The following is a description of a gene set: species: Homo sapiens Human Gene Set: GOMF_MOLECULAR_ADAPTOR_ACTIVITY The binding activity of a molecule that brings together two or more molecules through a selective, non-covalent, often stoichiometric interaction, permitting those molecules to function in a coordinated way., and this is the list of marker genes: CBX2, STRIP1, ZNF432, KCTD17, TOB2, FBXL2, DNAJC2, NUPR1, KLHL5 (kelch like family member 5), SPIN2B, TONSL, TMEM81 (transmembrane protein 81), ECSIT, KLHL21, MED14, TBL1X, SORBS1, MDC1, LDLRAP1 (low density lipoprotein receptor adaptor protein 1), EOMES, PSMG3, MYD88, IRGQ, WDR5, SPEN, USP15, ATN1, KBTBD8, EP300, RALY, MAP2K1, VCL, USP22, PARTICL, AR, RXRG, NLRP6, DCAF12 (NCBI Gene Id 25853), MAD2L2, HCFC1, MYH9, PRAMEF15, SLC35D3, ZNF410, PRAMEF18, KDM5B, VAMP7, SPATA18, GNB3, DHX9, DLG1, NIPBL, GNB5, CNOT9, LGALS3, FCRL2, MYOCD, FMR1, STX10, HSBP1, YAP1, ELOC, CARD8, WBP2, SNCA, LMO4, KLHL15, BUD31, INSM1 (INSM transcriptional repressor 1), CNOT2, UBE3A, MBD2, CDC42SE2, GCN1, SOCS7 (NCBI Gene Id 30837), NOC2L, DDX3X, MMS19, AMBRA1, CCAR1, RIPK1, KAT2B, KLHL20, RLIM, NSD1, SPIN4, EZH2, IQGAP1, DCAF1, GRB10, ILK, ARGLU1 (NCBI Gene Id 55082), AJUBA, SUFU, WWTR1, SERTAD2 (NCBI Gene Id 9792), WNT3A, PRAMEF19 (NCBI Gene Id 649338), MED12, POU2AF1, CD3G, RAB11FIP3, YAF2 (YY1 associated factor 2), TLE6, KLHL35, SFMBT2, MAPKAP1, PEX26, APBB3, LPXN, MED29, SMARCD3, MAPK8IP1, SPIN1, LETMD1, RBPMS, ZNF618, IGF2BP2, PRAMEF25, HDGFL2, TLE4, KGD4, HNRNPC, BBLN (NCBI Gene Id 95825), WIPF1, SMARCC2, PML (NCBI Gene Id 5371), KLHDC2, KLHL41, PEF1, TBL1XR1, PDCD6, FOXA2, PLCB3, TRIB3, TREX2, PRAMEF33 (NCBI Gene Id 645399), NEAT1, URI1, ZNF598, FBXO31, MLIP, TJP2, ACP3, NCOA3, CBX4, PCBP2, SAP30L, MYOZ1, HCLS1, PRPF6, TRAF5, BBS4, ITSN1, MED20, FSCN1, TRIM62, RRAGD, TRIM6, SP100, EIF4G1, LDB2, PDZK1, AP1G1, LDLR, TRAF3IP3, RYBP (NCBI Gene Id 23429), LPL, DZIP1, ENSG00000227733, PRKN, PSMG2, FHL2, SHARPIN, IRS1, LIN7B, TCOF1, SIKE1, GET1, TICAM1, IQCB1, PQBP1, TRIM25, KMT2C, SPSB2, SYN1, COPS5, INTS4, RUVBL2, BCL2, TRIM37, TRIM31, DTX3L, ATG16L1, IFNAR1, TADA1, SUPT20HL1, CNTLN, LIMD1, HDAC9, DYRK1A, BTAF1, APBB2, DNMT3B, FEM1B, YEATS4, STX12, COL14A1, DMAP1, STAP2 (NCBI Gene Id 55620), MTA1, CIB1, PEX14, VGLL1, WIPI2, TPX2, KLHL24, LMO1, POU2AF2, LMO2, TDP2, MORN3, BRD2, CCDC124, CHCHD3, CSTPP1, PRDM16, SMARCA2, HOMER1, SPIN3, GOSR2, TP53BP1, NRIP1, TRIM13, BTG1, NFATC2, LAT, ATG2B, ANAPC1, GFI1, HMGB2, TUT1, RCOR3, SDCBP, PPTC7, CARD10, MED30, VIM, LRWD1, EN2, LCOR, DCAF6, STUB1, KLF4, SPSB4, SRSF2, EDF1, SPACA6, CNOT6, CENPJ, BICD2, PDE4DIP, AP4E1, TOPBP1, DPM3, NCOA2, EPB41L3, LINC02591, ZXDC, BIN3, HDAC7, SAP30, PIK3R1, FIS1, CIDEB, TADA2B, CTNNB1, NHERF1, PPP2R2D, SGTA, STX1B, APH1A, HR, STX16, ECPAS, FRS3, STX2, MEG3, TADA3, TRIM27, SKP2, BET1, SCAI, GLYR1 (glyoxylate reductase 1 homolog), VAPB (NCBI Gene Id 9217), RCOR2, ZSWIM8, CRTC2, ERCC6, BRD3, MAP2K4, SARS1, COL4A4, RBM14, CAV2, SART3, RACGAP1, FBXO45, MSL2, SEPTIN4, KAT5, MARK4, NOTCH1, FIRRE, MED17, YWHAE, TRIM8, KBTBD6, PHF8 (NCBI Gene Id 57793), TAF1, HYAL2, HNRNPU, WWC2, HSPA1A, IGF2BP3, NELFA, AHDC1, FSCN2, TELO2, BEND6, SUPT3H, SHC1, FADD, TRAF6, SERTAD1, FBXO9, TLE2, FLRT1, CDCA4, DPF2, FGA, CREBBP, MRTFA, ACSS2, ENO1, DDRGK1, PRAMEF22, EWSR1, WNK3, SEPTIN14, TMF1, ALDOB, GRIP1, VAMP8 (vesicle associated membrane protein 8), CUL2, GMNN, APH1B, TRAF4, TCAP, WDR77, LAMTOR3, MID2, NCK2, MAML2 (NCBI Gene Id 84441), GNB2, MSH6 (NCBI Gene Id 2956), ZCWPW1, KLHL3, IGF2BP1, ENY2, GRB14, GAS2L1, IPPK, SYNE2, RCOR1, KMT2D, CASC11, AKAP9, ATF7IP2, TAPBP, CIITA (class II major histocompatibility complex transactivator), GATAD2A, TBL1Y, NFE2L2, MED24, PRAME, FBXO38, SUPT20HL2, SPSB3, TRIM14, TRIM17, TIRAP, TRADD (TNFRSF1A associated via death domain), A1CF, CUL1, PRAMEF26, ZCWPW2, DNAJB1, CAMTA1, HNRNPA2B1, TAF6, DDX1 (DEAD-box helicase 1), RUNX1T1, SEPTIN1 (NCBI Gene Id 1731), FKBP5, MED22, ANAPC7, PMF1, SH2D1A, RBM47 (NCBI Gene Id 54502), KRTCAP2, COL19A1, SURF6, MPHOSPH8, KDM2B, PRAMEF11, KDM2A, MALAT1, RBFOX2, FAN1, HSP90AA1, RPTOR, ABT1, SH2B2, PARK7, COL11A1, ZFPM1, DOT1L, PRAMEF17, ELOF1, MICALL1, KBTBD7, UBE2Z, OTUD4, SEPTIN2, ID2, PCLAF, CBX5, NAPA, DNMT3A (NCBI Gene Id 1788), STX7, SERINC1, PRKCB, PRMT2, ANKRD13B, XPC, NPAT, FBXO11, BCL10, NFKBIZ, SKP1, SEPTIN10, PTPN11, INTS6, AIP, KBTBD3, YTHDF2, TAF9B, MLLT3, CAV3, CCDC38, AXIN2, PRAMEF1 (PRAME family member 1), IFI27, PAWR (NCBI Gene Id 5074), ZMYND11, PWP1, ANKRD13D, NR0B1, NDC80, PRAMEF20, IFNAR2, FLRT3, KAT2A, NAB2, TIAL1, RAP2C, NBN, ING5, AP1M2, MBTD1, STON2, CUL7, KAT6A, PSMD9, VAMP1, AKAP13, MED1, PEX1, ARID1B, AP2A2, PACSIN2, IL31RA, NRG1, CAPRIN1, VPS11, TAF11, SUZ12, MYCBP, FAM81A, SMARCD2, PSMG1, SAYSD1, MIER2, HDAC4, CITED4, SPATA2, WDR73, MED13L, SRRT, HERPUD1, APBB1, MORC3, TDRD3, SMAD7, CBFB, CCDC62, NEFL, PKM, KLHL7, TBX6, KBTBD2, KSR1, ZIC3, MORC4, PA2G4, TP53, PRNP, ZFP36, DAXX (NCBI Gene Id 1616), CRYM, MTF2, SEPTIN12, RBCK1, LPIN3, GOSR1, COL8A2, ID1, IFI6, PAXX, MED27, SDR16C5, BIRC2, EEF1A1, OBSL1, GNB4, PHF13, RRAGA, KLHL22, KDM5A, DAB2IP, TAF9, CRKL, DDX20, KLHL38, TANK, EMILIN1, KLHDC1, ING1, MAPK8IP3, MIS18A, SCRIB, STON1, FBXL19, QKI, MED19, NIBAN2, SNW1, TAB2, PRMT5, PFDN5, HELZ2, TTLL12, DDIT3 (NCBI Gene Id 92982), MAVS, MSI1, PPP1R3C, NIPSNAP2 (nipsnap homolog 2), MTMR3, SSBP3, STX6, ALG14, CAPN3, WWOX, TRIM22, ZC3H18, DTL, PPARGC1A, USP21, FZR1, DAB1, SF1, MED31, GIGYF2, ID3, MED26, FXR1, NUFIP1, LAMTOR1, HMGA2, AIMP2, ZXDB, WWC3, OPTN, ARMC5, KDM1A, KSR2, NCAPG2, SLC30A9, TSG101, PKN1, VGLL2, CRTC1, SS18, POU2AF3, USP16, RIPK2, PRAMEF6, LINC01783 (long intergenic non-protein coding RNA 1783), STX11, PRDM8, TOX3, LMCD1, L3MBTL1, RB1CC1, NUP153, ANKRD9, AMFR, KCTD1, PHF19, MSL1, MUC1, EPC1, MAGED1, TLE7, TRIP11, SH3BGRL, SAP18, PSMC3IP, SETD3 (SET domain containing 3, actin N3(tau)-histidine methyltransferase), BCLAF3, G3BP2, PCBD1, SIN3A, HIF1AN, KHDRBS1 (KH RNA binding domain containing, signal transduction associated 1), STAT3, YTHDF1, CDY2A, BFAR, SLC4A1, ATP1B2 (NCBI Gene Id 482), HSBP1L1, CDYL2, HDAC3 (histone deacetylase 3), PUS1, LTBP1, PSMD4, FBXW7, DPPA3, SOCS6 (NCBI Gene Id 9306), AKIRIN2, RAD17, SLA2, C1QBP, KMT5A, SEPTIN9, DOK2, HRAS, ARHGAP26, TOMM70, PPARGC1B (NCBI Gene Id 153346), ARRDC4, MAGI2, CITED2, HSPA8, FHL5, INSC, ATG2A, JUND, SUB1, SH2B3, JAG1, CHD1, MYSM1, ASB1 (NCBI Gene Id 51665), PCNT, ANK3, DOK7, BCORL1, ADGRL3, PARP10, PRAMEF9, ANK2, MIDEAS, KLHL4, PIAS4, CDKN1B, PBXIP1, SSX1, DNAJB2, SNAP23, RACK1, PEX6, PRAMEF7, NAPB, LOX, WWC1, NIPSNAP1, ST13, TAB3, DDX4, EHD4, SOD3, GPHN, EXOC7, SMARCE1, CDY1, HTN3, CAV1, NCOA6 (nuclear receptor coactivator 6), TRAF3, MAP3K10, SFR1, KLHL1, AKAP6, TRIM24, PEX3, RICTOR, BAG6, NAB1, FXYD2, ACTN4, TBC1D31 (NCBI Gene Id 93594), ANKRD13A, PRDX4, TAB1, STX19, RETREG3, JMY, BLOC1S6, PGLYRP1, DRAXIN, DDX54, ABI2, CREG1, PHB1, BTRC, PIAS1, CNOT7, BNIP1, TGFB1I1, SEC22A, AKIRIN1, THAP7, MIER1, TOB1, FUS, BNIP3, DCAF13, MAP1A, CD274, SMARCA4, ZMIZ2 (zinc finger MIZ-type containing 2), KAT6B, AP1S2, RETREG2, SMARCC1, EID1 (EP300 interacting inhibitor of differentiation 1), RHNO1, RNF14, KEAP1, ATRX, SIN3B, ASB9 (ankyrin repeat and SOCS box containing 9), LIN28A, CBFA2T2, SH2B1, TGFBR2, CITED1, MED13, SND1, NFKB1, NCOA4, CCND1, RBBP8, DCAF7, KLHL40, ARPC4 (NCBI Gene Id 10093), PWWP2A, ING4, ROPN1B, RUVBL1, SEC22B, SASH1, VHL, CEP63, NUCKS1, STX3, LAMTOR2, UBXN8, HMGB1 (high mobility group box 1), ITGA2B, KLHL28, BMAL1, TRIM11, HCST, ABL1, IRAK1BP1 (NCBI Gene Id 80793), ATXN7L3, KLHL11, NUP62, ALYREF (Aly/REF export factor), CDYL, CTCF, ABI1, CRTC3, KLHL2, KCTD15, ING3, PRAMEF14, TRIM5, IRF2BP2, ERG28, DLGAP4, PIR, RBX1, PDZD11 (PDZ domain containing 11), PPP2R3A, VAMP2, CCNT1, FGF2, PPP2R2A, CAMTA2, SORBS2, KDM4C, CNKSR1, TRIM38, ERCC8, EIF3B, TLE5, CIR1, MAK, MPP7, AXIN1, FHL3, CD3E, RRP8, PRAMEF27, MECP2, CHD1L, MED15, UBE2L3, PIAS2, NME2, LBR, CSNK2B, LRRC75A, TRERF1, PAGE4, RAG2, EID2, GAB2, OFD1, MAML1, SCIMP, YTHDF3, AASS, PKP2, TNRC6A, JADE1, NACA, BAIAP2, BET1L, PTENP1-AS, CEBPZ, CRADD, RAPSN, STK38, MED18, RRP1B, SYT1, MTMR4, COX7A2L, KLHL8, CBFA2T3, GAS6, BRD4, DUSP19, TRAT1, KLHL6, IFI27L1, DEDD2, SH3RF1, CUL4A, SEPTIN6, HSH2D, H2AX, BASP1 (NCBI Gene Id 10409), ARK2N, ZBED1, SUN2, STX1A, LINC03126, ZNF764, SEPTIN11, SNAP47, DLG5, PHF10, IRF4, MED23, LPIN2, NEFH, ATP1B1, BCL9, MED6, FBXO7, SP1, STX17 (syntaxin 17), NPM1, BICD1, SPOCD1, TRIM52, PDLIM1, DLGAP1, TRIM21, BTG2, TDG, IKBKG, KLHL29, NLRP3, NLRP12, PCM1, FNTA, CIDEC, LINC01145, NCOA1, SHANK1, YTHDC1, ISCU, DAW1, SPTBN4, GAN, RBM33, TAF5L, PIH1D1, GON4L, ABI3, MED10, PPP1R13L, TSC22D1, TPR, FSCN3, FRMD4A, PHF1 (PHD finger protein 1), VAMP3, TACC1, FREY1, VCP, TRABD, SMYD1, PRPF31, CUL5, ARID3A, ZAR1, KLHL17, HYDIN2, KLHL10, FBXW8, MIDN, CDY1B, MAP2K2, AP2S1, WTIP, MED16, DLGAP2, NCOR2, PARP15, SLC9A1, ARID5A, BANK1, MTA2, GPS2 (G protein pathway suppressor 2), GOLPH3L, VTI1B, GAB1, IRAK2, FAAP20, WDR59, PAQR4, BCL3, ATP1B3, RNF20, USP18, RGS14, TAF3, ARL2BP, MYBBP1A (MYB binding protein 1a), NMNAT2, RAPGEF4, RETREG1, RAD50, SEPTIN8, MED7, KBTBD12, MED8, BRD8, ZMYND10, HCFC2 (host cell factor C2), AP1G2, ZMIZ1, PAQR3, SHB, CARD9, NUP98, ANKRD1, FAF2, UHRF2, FEM1A, ZNF541, PHF12, MRTFB, HMGA1, DISC1, EID2B (EP300 interacting inhibitor of differentiation 2B), ACTL6B, TAF7, TCP10L, BRCA1, STX8, RB1, MT-TS1, NCOA5, FEM1C, ATF7IP, TOLLIP, LAMP2, IVNS1ABP, G3BP1, KLHL23 (kelch like family member 23), FIZ1, BLNK, KLHL25 (NCBI Gene Id 64410), ING2, IRGM, KAT8, LDB1, RIOX2, PAG1, SGF29, ELANE, TAF15, TADA2A, MTDH, AP2A1, IPP, TLE3, GRB2, FBXW11, UTF1, SETD5, SEPTIN7 (septin 7, NCBI Gene Id 989), HPF1, TRIM55, MIER3, MSL3, VTI1A, SLMAP, NFE4, SUPT20H, SMDT1, SPIN2A, MAMSTR, AP2M1, ID4, PIAS3, H1-2, SUPT7L, CNOT1, TRAF1, E2F1, VPS18, KDM7A, NCSTN, STEEP1, WBP2NL, GOLPH3, BCLAF1, JUP, GAB4, LMO3 (NCBI Gene Id 55885), STING1, SQSTM1, BECN2, TRIP4, ZNF366, SH2D1B, WDR45B, TRAF2, SMARCD1, AIM2, KANK1, SUV39H2, FBXO46, NCAPD3, MEN1, WDR45, ACTL6A, SHANK3, KLHL30, LRRK2, ARID5B, HIP1, JAZF1, NR0B2, WIPI1, SS18L1, KDM3A, ALKBH5, GNB1, PARP14, FOXH1, BEX1, MED21, TBXT, AP1S3, ASB11, SAV1, DGCR8, SMARCB1, COL1A2, FBXO4, TICAM2, NKD2, CASP8AP2, NDC1, KRAS, IRS2, SPPL2C, FBXO3, CDH5, MTA3, CHD4, JCHAIN, PYGO1, AP2B1, LAMTOR5, KMT2E, TRRAP, STX18, PRAMEF10, EZH1, NFKBIB, SGTB, RIPK3, ZMYND8, STX5, ZNF451, CHD5, PHF2, OSTC, AP1M1, SPSB1, KLHL18, MLST8, NLRP4, NOS1AP, CPT1A, NOLC1, XIST, ARRDC1, APEX1, COPS2, STAP1, PTPN14, PRAMEF8, MYT1L, RPA1, SIAH2, H2AZ2, ASAH1 (NCBI Gene Id 79795), UHRF1 (ubiquitin like with PHD and ring finger domains 1), UBL7, HDAC1, CDY2B, DAB2, ATG14, HTATSF1, KAT7, ARRB1, SUN5, PRAMEF13, MLPH, SIRT1, GAB3, YKT6, RERE, PHF24, BRDT, NMNAT1, BCL9L, IRF2BP1, TYROBP, KDM4A, NHERF2, RUFY1, KLHDC3, PRAMEF4, ZNF354B, ZXDA, FKBP4, SYNE3, GAS2L2, CDC20, PRAMEF2, DET1, PRAMEF12, FBXO42, LPIN1, DDB1, NAPG, ADAP2, L3MBTL2, DDX17, YEATS2, CCDC134 (coiled-coil domain containing 134), DTX1, ANK1, RAD54L2, MED4, SARM1, IFI27L2, KLHL12, KDM3B, N4BP2L2, SEPTIN5, GTF2A1L, LIN7A, MKI67, TAX1BP1, TARDBP, SRA1, SOCS2, DHX16, TLE1, COL11A2, TAF6L, TRDN, KLHDC10, HIPK2, APPBP2, PPP1R10, CD53, PRAMEF5, SIRT6, HDGF, PPRC1, NCOR1, STRN3, RNF169, SNAP29, TAF12, SOS1, YTHDC2, SNAP25, ACTN1, SPAG9, ICE1, LIN7C (NCBI Gene Id 55327), RRAGC, UBQLN2, CGAS, TCERG1L, ZDHHC11, PHF14, ARF6, MAPK8IP2, PARP9, CCIN, TOX2 (TOX high mobility group box family member 2), DVL2, TRIM15, HCN2, SEPTIN3, NLRP1, FRS2, LIAT1, SFMBT1, CALCOCO1, STRN4, HAX1, HOMER2, TCERG1, RAB3A, PDZK1P1, FLRT2, ARID1A (NCBI Gene Id 8289), PPP4R2, POLD3, AEBP2, NCOA7, MED11, SUN3, CUL3, UVSSA, AP1S1, BCOR, MOB4, SRCAP, C1D, CBX8, GRAPL, PSMC6, AGER, DYRK1B, SUN1, HIRA, CARM1, NHERF4, FLYWCH1, CTBP1, BRD7, MICAL3, ITSN2, JMJD1C, FOXP3, COL4A2, THRAP3, XK, NMD3, NCK1, PER2, SYNE1, TSNARE1, ARRB2 (NCBI Gene Id 409), WNK1, ZNF653, AKAP5, CDK5RAP3, MED9, VAPA, UXT, ASXL1, LAMTOR4, HIP1R, NCBP1, SPAG4, CHD8, BARD1 (NCBI Gene Id 580), YBX1, CRK (NCBI Gene Id 1398), BAZ2A, WNT4, BRD1, DYNC1LI1, FBXL4, JARID2 (NCBI Gene Id 3720), BCL11A, MAML3, TRIP13, ZFPM2 (zinc finger protein, FOG family member 2), STX4, TRPC4AP, PSIP1, CXXC1, SETD4, DLGAP3, ACTN2, TRIM28, SHANK2, ERCC2, UIMC1, BECN1, PCMTD1, MED12L, KIR3DL1, CTBP2, USE1, SRSF3, TRIM32, MAPT